The following is a description of a gene set: Human Gene Set: GOMF_KINETOCHORE_BINDING Binding to a kinetochore, a proteinaceous structure on a condensed chromosome, beside the centromere, to which the spindle fibers are attached. species: Homo sapiens, and this is the list of marker genes: CLASP1, SPDL1, CENPH, CENPE, MAD1L1, TTK